Given this list of marker genes BAG4, PUS7, APOBEC1, HNRNPAB, RPUSD4, TRUB1, TRUB2, PUS7L, METTL3, RPUSD2, RPUSD3, SYNCRIP, PUS1, PUS3, DKC1, WTAP, A1CF, DNAJB11 (NCBI Gene Id 51726), METTL14, APOBEC2, here is a description of the gene set: The covalent alteration of one or more nucleotides within an mRNA molecule to produce an mRNA molecule with a sequence that differs from that coded genetically. Human Gene Set: GOBP_MRNA_MODIFICATION studied in species Homo sapiens